Given this list of marker genes HRAS, CAMK2A, ARL6IP6, PDE11A, TYRP1 (NCBI Gene Id 7306), PRKAR1A, HEXB, PUS3, FOCAD, GNA11, TASP1, here is a description of the gene set: A solitary, bluish, smooth surfaced macule, papule or plaque that is generally round or oval in shape. The histopathology of blue nevi varies by subtype, but general characteristics include a vertical wedge or bulbous shaped proliferation of spindle cells, dendritic melanocytes, and melanophages into a sclerotic dermis or subcutis. Human Gene Set: HP_BLUE_NEVUS species: Homo sapiens Blue nevus